The following is a description of a gene set: Top scoring trans-regulated expression quantitative trait loci (eQTL) influencing blood levels of high-density lipoprotein (HDL) cholesterol. Quantitative differences in gene expression are thought to contribute to phenotypic differences between individuals. We generated genome-wide transcriptional profiles of lymphocyte samples from 1,240 participants in the San Antonio Family Heart Study. The expression levels of 85% of the 19,648 detected autosomal transcripts were significantly heritable. Linkage analysis uncovered >1,000 cis-regulated transcripts at a false discovery rate of 5% and showed that the expression quantitative trait loci with the most significant linkage evidence are often located at the structural locus of a given transcript. To highlight the usefulness of this much-enlarged map of cis-regulated transcripts for the discovery of genes that influence complex traits in humans, as an example we selected high-density lipoprotein cholesterol concentration as a phenotype of clinical importance, and identified the cis-regulated vanin 1 (VNN1) gene as harboring sequence variants that influence high-density lipoprotein cholesterol concentrations. Human Gene Set: GOERING_BLOOD_HDL_CHOLESTEROL_QTL_TRANS from publication Göring HH, Curran JE, Johnson MP, Dyer TD, Charlesworth J, Cole SA, Jowett JB, Abraham LJ, Rainwater DL, Comuzzie AG, Mahaney MC, Almasy L, MacCluer JW, Kissebah AH, Collier GR, Moses EK, Blangero J (PMID 17873875) studied in species Homo sapiens, and this is the list of marker genes: EPB41L4A, MAPK8IP1, LDLRAD4, CYP4F35P, KLK3, TMEM241, NACC2, SELENON, MSI1, FLT4, ZC3HC1, PAF1, SCRIB, MPO